Given this list of marker genes Ecrg4, Irs2 (NCBI Gene Id 384783), Ffar1, Ghrhr, Gabbr1, Lrrc8a, Trpm5 (transient receptor potential cation channel, subfamily M, member 5), Tunar, Gpr27, Gpr68, Pfkfb2 (NCBI Gene Id 75925), S100a8, Trpc1, Snap25, Gck, Trpm2, Sct, Ucn, Bad, Itpr1, Tardbp, Slc2a2, C1qtnf12, Crh, Abat, Ghrh (NCBI Gene Id 14601), Myrip, Chrm3, Clcf1, Pdx1, Cacna1c, Ucn3, Gpr39, Pck2, Stim1, Prkd1, Ncoa6 (NCBI Gene Id 56406), Atg7, F2rl2, Hnf1a, Aacs, S100a9, Aimp1, Gper1, Cacna1d, Camk2n1, Cask, Lif, Selenot (NCBI Gene Id 70512), Hcfc1, Blk, Kiss1, Abcc8, Isl1, Abcg1, Orai1, Ptbp1, Ildr1, Mlxipl, Rab8b, Gip, Glp1r, Rph3al, Sirt1, Stx4a, Acsl4, Hfe, Gnas, Gcg, Nmu, Nkx6-1, Prkce, Mpc2, Ppp3cb, Lrp1, Mcu, Gpld1, Cckbr, Drd2, Gprc6a, Glul, Npy2r, Nlgn2, Ptger4, Rasl10b, F2, Arhgef7, Nadk, Fgg, Arrb1, Psmd9, Tfr2, Anxa7, Prkaca, Nnat, Vsnl1, Dynll1, Prkcb, Tm7sf3, Sirt3, Apln, Baiap3, Adora1, Egfr, Oxct1, Hif1a, Myh9, Adcy8, Gnaq, Grp, Tcf7l2, Fgb, Gja1, Sirt6, Capn10, Bglap2, Prkn, Ppard, Serp1, Cckar, Rapgef4, Cd38, Ghrl, Gipr, Pla2g6, Doc2b, Kif5b, C2cd2l, Osbp, Itsn1, Nr0b2, Casr, Tnfsf11, Fga, Ano1, Fto, Nr1h4, Sybu, Jak2 (Janus kinase 2), Gna11 (guanine nucleotide binding protein, alpha 11), Glud1, Pfkm, Adcyap1, Sox4, Trpa1, Trpm4, Agt (NCBI Gene Id 11606), Rbp4, Prkar1a, Rfx6, Plcb1, Rac1, Trh, Ffar2, Irs1, Slc30a8, Cftr, Pex5l, Oga, Ffar4 (NCBI Gene Id 209389), Lepr, here is a description of the gene set: Mouse Gene Set: GOBP_POSITIVE_REGULATION_OF_PEPTIDE_SECRETION species: Mus musculus Any process that activates or increases the frequency, rate, or extent of peptide secretion.